Given this list of marker genes Tfcp2l1, Nr5a2, Cdh1, Fgfr1, Rab26, Srp54a, Wls, Pdgfb, Tgfb1, Pax6, Dag1, Cdc42, Esrp1, Lama1, Tgm2 (NCBI Gene Id 21817), Ascl3, Lama5 (NCBI Gene Id 99115), Fgf8, Polb, Sox9, Ctnnd1, Il6, Ptf1a, Snai2, Insr, Twsg1 (NCBI Gene Id 71539), Nfib, Tgfb2, Edar, Esrp2, Fgf7 (fibroblast growth factor 7), Shh (sonic hedgehog), Pdgfa, Igf1, Ntn4, Cela1, Met, Clcn2, Nrp1, Pdx1, Igf1r, Btbd7, Sema3c, Eda, Fgfr2, Sema3a, Xbp1, Tgfb3 (transforming growth factor, beta 3), Fgf10 (NCBI Gene Id 14165), Nkx3-1, Plxnd1, Foxc1, Hgf, Tnf, Igsf3, Sox10, Igf2 (insulin-like growth factor 2), Plxna1, Bmp7, Muc19, Egfr, here is a description of the gene set: Mouse Gene Set: GOBP_EXOCRINE_SYSTEM_DEVELOPMENT studied in species Mus musculus Progression of the exocrine system over time, from its formation to a mature structure. The exocrine system is a system of hormones and glands, where the glands secrete straight to a target site via ducts or tubes. The human exocrine system includes the salivary glands, sweat glands and many glands of the digestive system.